Given this list of marker genes ZEB2, AQP7, SEC14L1, LYL1, NFYB, SERPINB9, GPR65, ACADL, KRTAP8-1, STAT3, MUC1 (mucin 1, cell surface associated), IFI35, MAP3K5, GPR146, DDX6, SLC66A2, NECAP2, CDK16, PPP2R2A, ANGPTL3, CNN3, VPS54, SLFN12, EAF2 (NCBI Gene Id 55840), SHFL, RNF149, CLIC4, CHD7, BST2, DNAJA2, PSMD5, GRIK5, ZNF574, IL9R, DTNBP1, SPSB1, COL17A1, TBX21, SESN3, ANGPTL2, MCOLN3, ID2, MAN1A1, ZNF281, APAF1, TRIM60, PARP12 (poly(ADP-ribose) polymerase family member 12), PSMA2, TPR, TRIM8, PGS1 (NCBI Gene Id 9489), C1orf52, TEAD4, USP29, CD53, ICAM1, SYNGR2, SRPK2, MAP1B, TIE1, IRF8, CRLF2, JUND, FABP7, IKZF4, TRIM34, TAB2, AGO2, ADA, UXT, UHRF1, NDRG3, PHF12, PUM1, PSMA3, HIF1A (NCBI Gene Id 3091), SAMSN1, MRPL52, ZFP36, RCHY1, RASA1, FPR1, INTS5, PTGR2, ISG15, ACVR1, CYP11A1, CREB3L2, SOCS3, MCM4, BLTP3B, HOOK2, ZBP1, PPP1CC, TXNRD1 (thioredoxin reductase 1), GPX8, PLA2G12A, DYNLT4, WDR86, CTNNBIP1, PLAAT3, AHSP, SYNE2, SPSB2, NEFH, ZNRF1, B3GAT1, CTSB, RBM10 (RNA binding motif protein 10), NOTCH4, STX12 (NCBI Gene Id 23673), IER5, PRKG1, FOXO1, SFMBT1, FURIN, FGFR1, GZMB, FTCD, IL18BP, CRABP2, SENP1, IQGAP2, PABIR1, EGFL8, PRIM2, CIPC, SLC6A6, TWSG1, ARID5A, CSTA, ENTPD2, JPH3, SEMA7A, OAS2, CCDC28A, PPP3R1, CNBP, LRRC57, CPD, CDYL, KPNA1, SAP30L (NCBI Gene Id 79685), BTK, GSTM3, SRXN1, LRP1, STK17B, GALC, DNASE2B, TNFSF8, IL3RA, ECM1, TMEM131L, PRDM1, NACC1, IFITM3, HELZ2, LPAR2, COX6B2, N4BP1, LAMP2, LAGE3, RNF121, LARP1, KLHL36, BIRC3, PSMD1, RNF157, CD2, AAGAB, IRF9, B3GNT3 (NCBI Gene Id 10331), ZEB1, GIMAP7, TRPS1, EMP1, NUDT6, OR2S2, PTPN1, BORCS7, NUDT13 (nudix hydrolase 13), ETV6, IFITM2, SIGIRR, AGPAT3, SNX6, C8orf82, AHR (aryl hydrocarbon receptor), DYNLL2, DDR1, SGK1, KMT2A, WFS1, CDKN2D, RER1, MAP4K3, ZFPL1, LBH, CBX4, here is a description of the gene set: species: Homo sapiens from publication Ng SY, Yoshida T, Zhang J, Georgopoulos K (PMID 19345118) Genes up-regulated in hematopoietic stem cells versus lymphoid primed multipotent progenitors. Regulation of lineage potential and transcriptional priming by Ikaros. New insight is provided into a bivalent regulation of lineage priming in the HSC and its lympho-myeloid restricted progeny the LMPP by the lymphoid lineage-determining factor Ikaros Whereas Ikaros is responsible for the activation of a cascade of lymphoid expression programs and for the establishment of lymphoid potential from the HSC to the LMPP it is also responsible for the repression of stem cell and erythroid genetic programs that are incompatible with further lineage restrictions emanating from the LMPP Human Gene Set: GSE15330_HSC_VS_LYMPHOID_PRIMED_MULTIPOTENT_PROGENITOR_UP